The following is a description of a gene set: Mouse Gene Set: GOBP_ENDOTHELIAL_CELL_DEVELOPMENT The progression of an endothelial cell over time, from its formation to the mature structure. studied in species Mus musculus, and this is the list of marker genes: Heg1, Id1 (inhibitor of DNA binding 1, HLH protein), Met, S1pr2, Clic4, Plcb1, Afdn, Cldn3, Ednrb, Ppp1r16b, Ednra, Icam1, Rap1a, Plod3, Sox18, Rapgef2, Ren1, Edn1 (NCBI Gene Id 13614), Tnfrsf1a (tumor necrosis factor receptor superfamily, member 1a), Pecam1, Magi1, S1pr3, F2rl1, Tnf, Cldn1, Ccm2, Robo4, Tjp2, Amotl2, Tnmd, Pde2a, Hoxa13, Vegfa, Gpx1, Cnmd, Myadm, Arhgef26, Marveld2, Rapgef3, Rock1, Rap2c, Vezf1, Fasn, Dmd, Col18a1, Ift88, Hpse, Proc, Ubiad1, Dicer1, Rdx, Msn, Ezr, Add1, Cdh5, Vcl, Notch4, Stc1, Rapgef1, Hapln2, Myd88, Akap11, Rap1b, Zdhhc21, Ptprs, Tjp1, Il1b, Pde4d, Foxp3, Mir874, Agt, Cldn5, Ikbkb, Rock2, Tjp3, F11r, Abcb1b